The following is a description of a gene set: Reactome Pathway: C-type lectin receptors (CLRs) Pathogen recognition is central to the induction of T cell differentiation. Groups of pathogens share similar structures known as pathogen-associated molecular patterns (PAMPs), which are recognised by pattern recognition receptors (PRRs) expressed on dendritic cells (DCs) to induce cytokine expression. PRRs include archetypical Toll-like receptors (TLRs) and non-TLRs such as retinoic acid-inducible gene I (RIG-I)-like receptors, C-type lectin receptors (CLRs) and intracellular nucleotide-binding domain and leucine-rich-repeat-containing family (NLRs). PRR recognition of PAMPs can lead to the activation of intracellular signalling pathways that elicit innate responses against pathogens and direct the development of adaptive immunity.<br>CLRs comprises a large family of receptors which bind carbohydrates, through one or more carbohydrate recognition domains (CRDs), or which possess structurally similar C-type lectin-like domains (CTLDs) which do not necessarily recognise carbohydrate ligands. Some CLRs can induce signalling pathways that directly activate nuclear factor-kB (NF-kB), whereas other CLRs affect signalling by Toll-like receptors. These signalling pathways trigger cellular responses, including phagocytosis, DC maturation, chemotaxis, the respiratory burst, inflammasome activation, and cytokine production. part of: Innate Immune System studied in species Homo sapiens, and this is the list of marker genes: UBE2D2, MUC17, CASP8, RELB, ITPR3, PSMB4, UBA52, PRKACB, IL1B, RPS6KA5, KRAS, ITPR2, UBE2N, NFKB1, EP300, MUC15, CLEC4A, PDPK1, NFATC2, SKP1 (S-phase kinase associated protein 1), CALM1, PSMA1 (NCBI Gene Id 5682), PSMA7, ITPR1, PSMA2, MUC13, AHCYL1, IKBKB, MAP3K14, CLEC10A, CARD11, MUC7, TRAF6, env, SRC, PSMC4, PSMB7, MUC3B, NFATC3, PPP3R1, PSMD12, PAK3, CDC34, NFKBIA, MUC5B, CHUK, PSMC2, RELA, PSMB1, PSMA3, UBE2M, PPP3CB, PSMD7, PSMC6, PSMB6, PRKACA, PRKACG, FYN, FBXW11, PRKCD, PSMD14, PSMB2, PSMC5, MUC6, HRAS, PSMC3, IKBKG, RPS27A, ADRM1, TAB3, RAF1, CLEC6A, MUC5AC, PSMD1, UBE2V1, PSMD11, PSMB3 (NCBI Gene Id 5691), PSMA5, NFATC1, UBA3, MUCL1, SYK, PSMD3, MUC12, PSMD8 (proteasome 26S subunit, non-ATPase 8), MAP3K7, LYN, CD209, MUC3A, CARD9, UBE2D1, MUC20, BTRC, PPP3CA, MUC21, PLCG2, MUC1, CLEC7A, PSMA6, MALT1 (NCBI Gene Id 10892), NRAS, PSMC1, UBC (NCBI Gene Id 7316), CLEC4C, PAK2, PYCARD, CCL22, CCL17, PAK1, TAB2, BCL10, ICAM3, CUL1, PSMD13, NFKB2, CLEC4E, PSMD6, MUC2, MUC4, FCER1G, TAB1, PSMB5, MUC16, ICAM2, PSMA4, PSMD2, UBB, CLEC4D, SEM1, MUC19, CREBBP